Given this list of marker genes EXOC4, FOXO3, CPNE1, SDHA, ACTN4, SLC2A9, CD320, DCTN2, INTS6L, RBBP9, PDXK, NAGA, RBM15B, ZFP36L2, RNF187, MAD1L1, ADSS2, ASPSCR1, ANXA4 (annexin A4), FAM120A, COMMD1, FIG4, SLAIN2, WDHD1, COPS2, CTNNBIP1, IL1R1, SLC40A1, RGL2, TMCO6, USP22, SEPHS2, CHEK2, MED30, SCNM1, STK38, LRPAP1, INPP4A, ZFX, SNX15, KCNAB2, SDHD, EPCAM, ETFDH, GID4, NCOA3, SIAE, LIPA, MSRB2, MMP15, TM7SF3, SNTA1, GNAS, RASSF5 (NCBI Gene Id 83593), FAHD1 (NCBI Gene Id 81889), SERINC3, SLC25A39, CFAP20, FRRS1, TMEM129, RAP2A, CD109, ACTR8, ABCB1, TFEB, FAM53A, SLC16A7 (NCBI Gene Id 9194), MAST3, TPCN1, EPB41, GBA2, ASB3, PTTG1, GALNS, MEPCE, MBTD1, CYP2C8, LAT2, NGLY1 (N-glycanase 1), BPHL, HACD4, FEZ2, KIF13A, IDH3B, MAPK3, IVNS1ABP, HERC4, KLHL22, SNHG6, GMNN, PRRG2, RGS1, RNF123, CDC6, CEP89, NRDE2, MTA1, POLR2I, ITGAX, ACP1, UBE4B, AGBL5, TM6SF1, SSBP3, ATP13A2, CENPB, DMAC2, COMT, PDE8A, AKR1E2, SPON1, ZFPM1, KEAP1, METTL27, ELP3, OSGEP, RAD50, ACADM, POLR2A, SLC25A26, GLIPR1, AKR1B1, CALR, KDM2B, RCAN3, TLE1, KIAA0319L, TTC5, PCMTD2, NAGK, PRKAG1, KIFC3, TPGS2, PRPS1, MED25, CBX2, CHD6, TBC1D23, SMPD5, BAG4, MEA1, KIFAP3, D2HGDH, WDSUB1, ITPR3, PEDS1, ZNF746, ERLEC1, NAXE, NATD1, PGGHG (protein-glucosylgalactosylhydroxylysine glucosidase), NAA20, AP3M2, DOP1B, TRPV2, CTDSP2, GLRX2 (NCBI Gene Id 51022), RPA1, NCLN, DDHD2, RPL7A, PRKACB, SLC25A20, ADRA1A, KLF9, KGD4, NCSTN, METTL8, CXorf38, TCEAL9, RNF167, TDP2, ARHGAP17, CEP57L1, CNPPD1, SMARCA2, SIGMAR1, GGA2 (golgi associated, gamma adaptin ear containing, ARF binding protein 2), UBR3, ASPH, DHRS3, SRPK2, MMAA, TPGS1, FBXW4, MAP6, ACAA2, QPCT, SLC41A1, MIS18A, H6PD, ALDH2, QKI, RSPH9, CDADC1, RMND5B, MNT, ABHD4, CYB561D2, NME3, here is a description of the gene set: from publication Usher MG, Duan SZ, Ivaschenko CY, Frieler RA, Berger S, Schütz G, Lumeng CN, Mortensen RM (PMID 20697155) studied in species Homo sapiens Human Gene Set: GSE23308_WT_VS_MINERALCORTICOID_REC_KO_MACROPHAGE_UP Genes up-regulated in macrophages: wildtype versus NR3C2 knockout. Inappropriate excess of the steroid hormone aldosterone, which is a mineralocorticoid receptor (MR) agonist, is associated with increased inflammation and risk of cardiovascular disease. MR antagonists are cardioprotective and antiinflammatory in vivo, and evidence suggests that they mediate these effects in part by aldosterone- independent mechanisms. We used affymetrix to characterize the effect of Mineralocorticoid Receptor deletion on macrophage transcriptional profile, and identify its requirement in normal glucocorticoid signalling.